The following is a description of a gene set: Human Gene Set: GOBP_POSITIVE_REGULATION_OF_EXOCYTOSIS studied in species Homo sapiens Any process that activates or increases the frequency, rate or extent of exocytosis., and this is the list of marker genes: F2RL1, SYT7, ITGB2, CLASP2, VSNL1, KCNB1, IFNG, VPS4B, RAB15, HYAL3, CLASP1, CD160, CHMP2A, SYK, DOC2B, ATP13A2, CD177 (CD177 molecule), SDCBP, CADPS2, SYT10, DOC2A, HGS, ZP3, SCAMP5, CADPS, RAB9A, SYT4, FGG, SDC4, GAB2, HLA-F, SNF8, VPS4A, ANXA2, IL13, RAB3D, STX1A, ITGAM, GATA2, STXBP5, CFTR, STAM, SDC1, NLGN1, RAB27A, RPH3AL, FGA, LAMP1, KLRC2, STXBP1, ADORA2B, PPP3CA, FCER1G, PDCD6IP, VAMP8, GATA1, CACNA1B, SYT1, VAMP7, RAB7A, SYTL4, FGR, FGB, RPH3A, EXPH5, S100A10, CDK5R2, IL4R, SNX4, SLC4A8, RAB2B, TSG101, PLA2G3, RAB5A, CDK5, UNC13D (NCBI Gene Id 201294), PRKCA, RAB3A, STX4, SMPD3, AP1G1, SNCA, RUFY4, RAB27B, SPHK2